Given this list of marker genes PARN, CCT8, TCP1, TINF2, TERC, RAD50, TERF2, SMG6, TNKS1BP1, NAF1, HSP90AA1, HSP90AB1, PTGES3, FBXO4, TEP1, TERF1, TENT4B, TERT, EXOSC10, TNKS, HMBOX1, NOP10, POLQ, PINX1, RFC1 (replication factor C subunit 1), CCT4, SMG5, PARP3, PML, RPA1, DKC1, WRAP53, DCP2, TP53 (tumor protein p53), CTC1, PIF1, CCT5, CCT6A (NCBI Gene Id 908), XRN1, NAT10, HNRNPU, ATM, HNRNPA1, MRE11, STN1, XRCC5, CCT7, CCT2, NHP2, HNRNPC, CTNNB1, TEN1, ATR, CCT3, TERF2IP, HNRNPD, POT1, TNKS2, ACD, GNL3L, GAR1, here is a description of the gene set: species: Homo sapiens A DNA biosynthetic process that uses RNA as a template for RNA-dependent DNA polymerases (e.g. reverse transcriptase) that synthesize the new strand. Human Gene Set: GOBP_RNA_TEMPLATED_DNA_BIOSYNTHETIC_PROCESS